Given this list of marker genes GMCL1, SMYD4, FAM111A, TSC2, MEN1, DET1, DPY19L1, FAM20B, DCLRE1A, SLC44A2, ACTN1, SEMA4F, NAAA, RAB3A, RRM2, SGO2, RPA3, CYB5R4, E2F7, CCNA2, COPG2, CCNH, SKP2, AKR1B10, CASD1, CCNB1IP1, CRMP1 (NCBI Gene Id 1400), BRAT1, MAN2A1, ZMYM3, KIF21B, ADD3, PEX10, H4C14, ACSF3, MCM4, FANCD2, TRIM21, FANCB (NCBI Gene Id 2187), TFDP1, POLE2, IL2RB, KIF11, TMED8, DIS3L, FOXK1, SPC25, SVIL, AMMECR1, ELP4, PRKACB, ZNRF2, KLF2, ST7L, AIFM1, RPP25, IFI44, CKAP5, NINJ2, SLC35A5, ANKRD44, PREX1, PYGB, TIPIN, INTS4, ESCO2, ZFP41, H2AC15, PPA2, HYLS1, APEH, C16orf54, TRIM65, ZBTB45, PRR12, RYK, SLC25A53, VPS13C, IMMT, SGO1 (NCBI Gene Id 151648), NAIF1, SUN1, PRC1, GYS1, EIF2AK2, E2F6, TNFSF10, OXSM, SYT11, TMX1, MTPN, SLC25A12, NSD2, ZDHHC6, CLCC1, METTL17, NR1I3, TTYH3, LARS2, RIPOR2, H1-5, THEMIS, ANAPC1 (NCBI Gene Id 64682), NCAPG, FIGNL1, FAM78A, RNASEH2B, FGL2, SLC33A1, ZMPSTE24, KLHL42, NELFCD, SLC39A10, GPAM, TADA3 (NCBI Gene Id 10474), H6PD, LRRC8C, WEE1, ADD1, TET1, TDP1, B3GLCT, AKAP1, TMPO, FLNB, SAE1, SLC39A3, ESYT1, ZC3H4, RPA1, HERC5, GEN1, SAMM50, NXPE3, PGD, PGBD1, CALHM2, HSH2D, IQCE, AASDH, VRK3, TOP2A, CD200R1L, KLHDC1, DEF8, CEP70, ARHGAP11A, TSPYL4, CS, TBC1D13, TONSL, IQGAP2, APBB1IP, HPSE, APLF, ELP2, IFIT2, XK, BICRA, DDX60, NUSAP1, POLH, HGSNAT, MAPDA, YEATS2, EXD2, MSH2, RAD50, CCDC15 (NCBI Gene Id 80071), DNAAF10, SEL1L, SIKE1, TCF3, XPO7, here is a description of the gene set: studied in species Homo sapiens IFNs are highly pleiotropic cytokines also endowed with marked anti-angiogenic activity. In this study, the mRNA expression profiles of endothelial cells (EC) exposed in vitro to IFN-alpha, IFN-beta, or IFN-gamma were determined. We found that in HUVEC as well as in other EC types genes were upregulated (>2-fold increase) by IFNs, including genes involved in the host response to RNA viruses, inflammation, and apoptosis. Interestingly, genes showed a >5-fold higher induction by IFN-alpha in EC compared to human fibroblasts; among them, the gene encoding the angiostatic chemokine CXCL11 was selectively induced by IFN-alpha in EC along with other genes associated with angiogenesis regulation, including CXCL10, TRAIL, and guanylate binding protein 1 (GBP-1). These transcriptional changes were confirmed and extended by quantitative PCR analysis and ELISA; whereas IFN-alpha and IFN-beta exerted virtually identical effects on transcriptome modulation, a differential gene regulation by type I and type II IFN emerged, especially as far as quantitative aspects were concerned. In vivo, IFN-alpha-producing tumors over-expressed murine CXCL10-11, GBP-1 and TRAIL, with evidence of CXCL11 production by tumor-associated EC. Overall, these findings improve our understanding of the anti-angiogenic effects of IFNs by showing that these cytokines trigger an anti-angiogenic transcriptional program in EC. Moreover, we suggest that quantitative differences in the magnitude of the transcriptional activation of IFNresponsive genes could form the basis for cell-specific transcriptional signatures. Genes down-regulated in endothelial cells: untreated versus interferon beta. Human Gene Set: GSE3920_UNTREATED_VS_IFNB_TREATED_ENDOTHELIAL_CELL_DN from publication Indraccolo S, Pfeffer U, Minuzzo S, Esposito G, Roni V, Mandruzzato S, Ferrari N, Anfosso L, Dell'Eva R, Noonan DM, Chieco-Bianchi L, Albini A, Amadori A (PMID 17202376)